The following is a description of a gene set: species: Mus musculus Mouse Gene Set: GOBP_ADENOSINE_TRANSPORT The directed movement of adenosine, adenine riboside, into, out of or within a cell, or between cells, by means of some agent such as a transporter or pore., and this is the list of marker genes: Slc29a3, Slc29a2, Slc29a4, Slc28a2, Slc28a2b (NCBI Gene Id 381417), Slc29a1